The following is a description of a gene set: Reactome Pathway: Processing of Intronless Pre-mRNAs The 3' ends of eukaryotic mRNAs are generated by posttranscriptional processing of an extended primary transcript. For almost all RNAs, 3' processing consists of two steps: The mRNA is first cleaved at a particular phosphodiester bond downstream of the coding sequence. The upstream fragment then receives a poly(A) tail of approximately 250 adenylate residues whereas the downstream fragment is degraded. The two partial reactions are coupled so that reaction intermediates are usually undetectable. While 3' processing can be studied as an isolated event in vitro, it appears to be connected to transcription, splicing and transcription termination in vivo. part of: Processing of Capped Intronless Pre-mRNA species: Homo sapiens, and this is the list of marker genes: NCBP1, SYMPK, PABPN1, CSTF1, CSTF3, CLP1, CSTF2, CPSF2, FIP1L1, CPSF1, CSTF2T, CPSF7, CPSF3, PAPOLA, PCF11, WDR33, CPSF6, NUDT21, CPSF4, NCBP2